Given this list of marker genes AIP, GLI3, NF2, TMEM67, TERT, SOX3, ARNT2, HID1, RBM28, BAP1, SMARCE1, SUFU, AKT1, GPR101, FOXA2, TRAF7, LHX3, HESX1, MEN1, TRHR, LEP, SMO, OTX2, PDGFB, POU3F4, LEPR, PCSK1, TSHB, POU1F1, LHX4, PROP1, CTNNB1, GLI2, PIK3CA, CDH23, POMC, BRAF, SMARCB1, here is a description of the gene set: studied in species Homo sapiens Pituitary hypothyroidism Human Gene Set: HP_PITUITARY_HYPOTHYROIDISM A type of hypothyroidism that results from a defect in thyroid-stimulating hormone secretion.